The following is a description of a gene set: A large (20 S) protein complex that possesses protein arginine methyltransferase activity and modifies specific arginines to dimethylarginines in the arginine- and glycine-rich domains of several spliceosomal Sm proteins, thereby targeting these proteins to the survival of motor neurons (SMN) complex for assembly into small nuclear ribonucleoprotein (snRNP) core particles. Proteins found in the methylosome include the methyltransferase JBP1 (PRMT5), pICln (CLNS1A), MEP50 (WDR77), and unmethylated forms of SM proteins that have RG domains. Human Gene Set: GOCC_METHYLOSOME studied in species Homo sapiens, and this is the list of marker genes: SNRPB, SNRPD2, SNRPG, ERH, SNRPF (small nuclear ribonucleoprotein polypeptide F), SNRPD1, PRMT5, FUT6, SNRPD3, PRMT1, CLNS1A, WDR77, SNRPE